Given this list of marker genes Ppif, Atg7, Slc38a2, Hmox1, Ddx3x, Zfand1, Zfand2a, Daxx, Gsto1, Zc3h12a, Hnrnpa1, Mknk2, Hsf1 (heat shock factor 1), Gsto2, Uros, D1Pas1, Vcp, Mapk13, Dhx36, here is a description of the gene set: studied in species Mus musculus Any process that results in a change in state or activity of a cell (in terms of movement, secretion, enzyme production, gene expression, etc.) as a result of an arsenic stimulus from compounds containing arsenic, including arsenates, arsenites, and arsenides. Mouse Gene Set: GOBP_CELLULAR_RESPONSE_TO_ARSENIC_CONTAINING_SUBSTANCE